The following is a description of a gene set: N-linked glycosylation is the most important form of post-translational modification for proteins synthesized and folded in the Endoplasmic Reticulum. An early study in 1999 revealed that about 50% of the proteins in the Swiss-Prot database at the time were N-glycosylated. It is now established that the majority of the proteins in the secretory pathway require glycosylation in order to achieve proper folding.<br>The addition of an N-glycan to a protein can have several roles (Shental-Bechor & Levy 2009). First, glycans enhance the solubility and stability of the proteins in the ER, the golgi and on the outside of the cell membrane, where the composition of the medium is strongly hydrophilic and where proteins, that are mostly hydrophobic, have difficulty folding properly. Second, N-glycans are used as signal molecules during the folding and transport process of the protein: they have the role of labels to determine when a protein must interact with a chaperon, be transported to the golgi, or targeted for degradation in case of major folding defects. Third, and most importantly, N-glycans on completely folded proteins are involved in a wide range of processes: they help determine the specificity of membrane receptors in innate immunity or in cell-to-cell interactions, they can change the properties of hormones and secreted proteins, or of the proteins in the vesicular system inside the cell.<br>All N-linked glycans are derived from a common 14-sugar oligosaccharide synthesized in the ER, which is attached co-translationally to a protein while this is being translated inside the reticulum. The process of the synthesis of this glycan, known as Synthesis of the N-glycan precursor or LLO, constitutes one of the most conserved pathways in eukaryotes, and has been also observed in some eubacteria. The attachment usually happens on an asparagine residue within the consensus sequence asparagine-X-threonine by an complex called oligosaccharyl transferase (OST).<br>After being attached to an unfolded protein, the glycan is used as a label molecule in the folding process (also known as Calnexin/Calreticulin cycle). The majority of the glycoproteins in the ER require at least one glycosylated residue in order to achieve proper folding, even if it has been shown that a smaller portion of the proteins in the ER can be folded without this modification.<br>Once the glycoprotein has achieved proper folding, it is transported via the cis-Golgi through all the Golgi compartments, where the glycan is further modified according to the properties of the glycoprotein. This process involves relatively few enzymes but due to its combinatorial nature, can lead to several millions of different possible modifications. The exact topography of this network of reactions has not been established yet, representing one of the major challenges after the sequencing of the human genome.<br>Since N-glycosylation is involved in an great number of different processes, from cell-cell interaction to folding control, mutations in one of the genes involved in glycan assembly and/or modification can lead to severe development problems (often affecting the central nervous system). All the diseases in genes involved in glycosylation are collectively known as Congenital Disorders of Glycosylation (CDG), and classified as CDG type I for the genes in the LLO synthesis pathway, and CDG type II for the others. Reactome Pathway: Asparagine N-linked glycosylation species: Homo sapiens part of: Post-translational protein modification, and this is the list of marker genes: OST4, DYNC1LI2, TMED2, SEC24B, COG5, GORASP1, CALR, ACTR10, TUBB2A, TBC1D20, GMPPA, MGAT1, CHST8, CTSZ, TRAPPC10, SPTA1, TRIM13, COG2, COL7A1, UBB, ARCN1, PGM3, SEC13, GFPT2 (NCBI Gene Id 9945), ST6GAL1, RPN2, ALG9, MAN1B1, COG6, NAPA, MGAT5, COPZ2, DPM2, TUBAL3, ARF1, GOSR2, ALG3, MPDU1, SEC16A, SLC35A1, BET1L, COPG2, F8, ACTR1A, GBF1, OSTC, TUBA1A, COPG1, ST8SIA2, TRAPPC5, ENGASE, UBXN1, B4GALT2, COPE (COPI coat complex subunit epsilon, NCBI Gene Id 80158), ST3GAL5 (ST3 beta-galactoside alpha-2,3-sialyltransferase 5), CNIH3, DPM1, TMED7, SAR1B, NANS, ST6GALNAC3, KDELR3, LMAN2, TMED3, GRIA1, MAN1A2, TUBB4A, NEU4, STT3A, B4GALT5, RFT1, CHST10, GOSR1, ST8SIA1, ALG10B, TRAPPC1, DPAGT1, MAN2A1 (mannosidase alpha class 2A member 1), TUBA3D, NEU2, MIA2, SPTBN5 (spectrin beta, non-erythrocytic 5), MGAT4A, DCTN3, DCTN1, DCTN2, EDEM1, DOLK, ST6GALNAC1 (NCBI Gene Id 55808), GFUS, TUBB6, SYVN1, CAPZA1 (NCBI Gene Id 829), SEC22A (SEC22 homolog A, vesicle trafficking protein), ALG2, B4GALT1, ST3GAL3, ALG5, CNIH2, FUT3, UAP1, GLB1, TRAPPC4, TUBB2B, ARF3, MOGS, TUBA1B (NCBI Gene Id 88851), SPTAN1, ARFGAP1, ST6GALNAC4, MCFD2, ALG11, NUDT14, COG1, NAPB, NUS1, GNE, COPZ1, DYNC1H1, SLC17A5, ARFGAP2, MGAT4C, ST8SIA6, NEU1, HK1, TRAPPC2L (trafficking protein particle complex subunit 2L), DCTN6, TMED9, FCSK, RENBP, NPL, DYNC1I1, CNIH1, TUBA1C, TMEM115, KDELR1, SEC24A, RNF185, SEC22C, ALG1, CD59, ST8SIA4, GFPT1, FPGT, COG4, PPP6R3, SCFD1, ANK2, ST3GAL4, DAD1, ST6GAL2, AMDHD2, NANP, MGAT2, MAN2A2, MAGT1, COG3, ST3GAL6, TMEM258, CGA, COG7, UGGT2, DOLPP1, ALG8, RNF103, TUBA4A, FOLR1, TRAPPC6A, MPI, RAB1A, DHRSX, F5, RNF139, MAN1C1, MVD, SEC16B, RPS27A (NCBI Gene Id 6233), NAGK, SLC35C1, CAPZA3, SEL1L, PMM2, NAPG, UGGT1, ANKRD28, TGFA, CANX, TRAPPC2, FUT8, MARCHF6, TUBA3E, ASGR1, AREG, SPTBN1, LHB, ARF4, SPTB, ALG14, CAPZB, MAN1A1, COPB1 (NCBI Gene Id 51664), ALG10, B4GALT4, RAB1B, DPM3, TUBA8, EDEM3, VCP, DHDDS, SEC23IP, SPTBN2, ASGR2, CAPZA2, DYNLL2, ALG6, PREB, CTSA, TUBA3C, ALG12, TUBB1, AMFR, LMAN1L, STX5, ST6GALNAC6, GOLGA2, DERL2, SEC31B, ANK1, CTSC, USO1, SEC22B, BET1, ST6GALNAC2, MGAT3, DCTN5, SEC24C, UBA52, DCTN4, STX17, LMAN2L, DERL1, DDOST, B4GALNT2, RAD23B, PDIA3 (protein disulfide isomerase family A member 3), ANK3, UMOD, YKT6, SERPINA1, MANEA, TRAPPC6B, LMAN1, DYNC1I2, INS, B4GALT3, GOLGB1, SPTBN4, ARF5, B4GALT6, UBC, OS9, FUOM, CSNK1D, GMPPB (GDP-mannose pyrophosphorylase B), ST8SIA3, FUCA1, DYNC1LI1, GANAB, EDEM2, TUSC3, ST6GALNAC5, STT3B, PPP6R1, MLEC, SEC24D, GNPNAT1, TRAPPC3, NGLY1, ST3GAL1, COG8 (component of oligomeric golgi complex 8), PPP6C, PMM1, TFG, RNF5, ST3GAL2, SRD5A3, CMAS, CD55, RPN1, NEU3, PSMC1, TRAPPC9, SEC31A, TUBB8, DYNLL1, SEC23A, KDELR2, ARFGAP3, TUBB3, TUBB4B, TMED10, TUBA4B, ST8SIA5, GMDS, COPB2, NSF, TUBB8B, COPA, ALG13, MGAT4B (alpha-1,3-mannosyl-glycoprotein 4-beta-N-acetylglucosaminyltransferase B), PRKCSH, MIA3